The following is a description of a gene set: Male reproductive system neoplasm studied in species Homo sapiens A neoplasm that affects the male reproductive system. Human Gene Set: HP_MALE_REPRODUCTIVE_SYSTEM_NEOPLASM, and this is the list of marker genes: WWOX, MAD1L1, AAGAB, BRCA1, PALB2, FOXE1, NR5A1, KLF6, RAD51, NR0B1, BRCA2, NAB2, NBN, MDM2, MRAP, AKT1, MAP3K1, DHX37, PTEN, MRE11, BMPR1A, RAD50, BARD1, MC2R, STAR, ZFHX3, KANSL1, NTHL1, CDKN2A, BRIP1, APC, IGF2, RNF43 (ring finger protein 43), PRKAR1A, RNASEL, STK11, WT1, RAD51D, PDE11A, ZFPM2, KEAP1, SOX9, COL14A1, DICER1, CDC73, RAD51C, TP53, NNT, SRY, STAT6, EPHB2, EWSR1, AR, MXI1, STS, VAMP7, CHEK2 (checkpoint kinase 2), CDKN1B, GATA4, GREM1, CYP11B1, FLI1, TXNRD2